Given this list of marker genes Qprt, Il4i1, Acmsd, Nadsyn1, Tdo2, Haao, Afmid, Kmo, Atp7a, Nmnat2, Tph2, Kynu, Cyp2d22, Gcdh, Ido1, Ido2, here is a description of the gene set: The chemical reactions and pathways involving indolalkylamines, indole or indole derivatives containing a primary, secondary, or tertiary amine group. Mouse Gene Set: GOBP_INDOLALKYLAMINE_METABOLIC_PROCESS species: Mus musculus